Given this list of marker genes COQ7, TERT, SPG7, FHL1, TCAP, PON3, SMARCB1, ERGIC1, SCN4A, GMPPB, TFG, CFAP410 (NCBI Gene Id 755), TARDBP, VHL, MYF6, LRP4, MFN2, SYNE1, ANO5, OBSCN, PFN1, VCP, GARS1, COL13A1, PON2, MATR3, CHRNB1, PDGFB, SPTAN1, IGHMBP2, GLE1, SLC12A6, ADAR, PIK3CA, CHMP2B, VAPB, CYP7B1, LDB3, ZFYVE26, MT-ATP6, MT-CO1, YARS1, DNMT3B, CFL2, SCYL2, SPART, DOK7, VWA1, PIEZO2, AKT1, SBF1, SNUPN, PDXK, SQSTM1, PLOD1, TRPV4, MTMR14, ACTA1, FARS2, UNC13A, ANG (NCBI Gene Id 283), LRP12, ATXN2, PPARGC1A, SMPX, TRAF7, HMGCR, HNRNPA1, MORC2, PRPH, FBXO38, FIG4, BSCL2, LIPE, LAMA2, MT-CO3, MTRFR, NUP54, ANXA11, GALC, CHRNE, DCTN1, DAO, AK9, CRPPA, TREM2, CHRND, NEFL, SGCG, NOTCH2NLC, PPOX (protoporphyrinogen oxidase), NUP62, CCNF, ERLIN2, TBK1, NEK1, CPOX, HEXB, DNM2, TMEM43, GDAP1, UBQLN2, SUFU, DYSF, KIF5A, EGR2, SBF2, B4GALNT1, JAG1, SYNE2, GLT8D1, SPG11, GYG1, ERBB4, RILPL1, SMO, OPTN, MPZ, AGRN, RAPSN, KY, FUS, POU3F4, RYR1, BAP1, HMBS, EMD, LMNA, NF2, FGD4 (NCBI Gene Id 619403), REEP1, COL25A1, LPIN1, JAG2, SH3TC2, BIN1, CADM3, TAF15, SEPTIN9, ADSS1, SOD1, CHRNA1, MUSK, SMARCE1, POMT1, PON1, NEFH, CHCHD10, GIPC1, CCND1, here is a description of the gene set: studied in species Homo sapiens Human Gene Set: HP_UPPER_LIMB_MUSCLE_WEAKNESS Weakness of the muscles of the arms. Upper limb muscle weakness